The following is a description of a gene set: studied in species Homo sapiens Human Gene Set: GOMF_1_4_ALPHA_OLIGOGLUCAN_PHOSPHORYLASE_ACTIVITY Catalysis of the reaction: 1,4-alpha-D-glucosyl(n) + phosphate = 1,4-alpha-D-glucosyl(n-1) + alpha-D-glucose 1-phosphate., and this is the list of marker genes: PYGB, MTAP, PYGL, PYGM, TYMP